The following is a description of a gene set: Leishmania major infected human dendritic cells (DCs) exhibit a marked induction of IL-12 ultimately promoting a robust Th1-mediated response associated with parasite killing and protective immunity. In this study, we utilized Affymetrix Genechips to globally assess the host cell genes and pathways associated with L. major infection during early infection (2, 4, 8, and 24 hrs) in human myeloid-derived DCs. Bioinformatic analyses of the hybridized microarray chips identified genes, represented by 848 unique probe sets, which, when compared to uninfected samples were observed to be significantly differentially expressed by one-way ANOVA. Altogether, the data provide a genome-wide perspective on the transcriptional influences Leishmania species exert within human DCs during early infection, and provides a platform for further investigations toward functionally characterizing candidate genes of importance to the IL-12 based immune response to infections. In the current study, we further investigate the L. major infected DC transcriptional during early time points after infection via microarray analysis. Genes up-regulated in dendritic cells: untreated versus 24h after infection of Leishmania major. Human Gene Set: GSE42088_UNINF_VS_LEISHMANIA_INF_DC_24H_UP studied in species Homo sapiens from publication Favila MA, Geraci NS, Zeng E, Harker B, Condon D, Cotton RN, Jayakumar A, Tripathi V, McDowell MA (PMID 24808365), and this is the list of marker genes: ZDHHC7, SUCLG2, NCOA3, KAT6B, EPRS1, CAST, IL10RA, SCPEP1, THEMIS2, RFC3, INPP4A, SF3B1, PCBP2, CCDC69, CHKA, SHB, KIAA0513, CASP9, LRRFIP1, TSPO, TXN2, CLCN3, NUCKS1, PHF20, CSDE1, LGALS9, RAD17, H1-10, PTK2B, ARHGAP45, PIGT, OXA1L, ZBED1, BAIAP2, ZFP36, SNRK, HMGB2, CENPC, POLB, PAK6, KLF4, RALGDS, CSF3R, MTMR12, EVI2A, FLI1, ZFP36L1, CSAD, SH3TC1, INPP5D, ITM2B, LBR, CELF2, SGSM2, ZNF117, MEF2C, HSPA14, PDK3, ACAP1, NACA, TSC22D3, PTPN22, ZBTB1, TLR4, ARHGAP4, SRSF5, SPATA20, VPS51, MACROH2A1, ALDH2, ZXDC, CBFA2T3, PIK3R1, ADPGK, CD302, CD69, RUNX3, EVI2B, TRMT5, FAM53C, RAP2B, HSD17B11, GSTK1, CYTH4, PPM1F, MANBA, IFNGR1, HLA-DMB, SPAST, MTX1, CRISPLD2, ZWILCH, RGS2, ASAH1, ABCB7, CSNK1G3, CSNK1G2, ITGA4, MAP3K2, ELF1, NLRP1, MXD1, PTGER4, SIPA1, TRAK1, DUSP1, DENND3, TACC1, CCNB1IP1, C5AR1, CERK, RNASET2, PRKCB, PECAM1, HMG20A, TYK2, TOR3A, RAB33B, ITGAM, PJA2 (praja ring finger ubiquitin ligase 2), CLEC7A, GAS7, IQSEC1, PTMA, GALNT11, COTL1, CD46, SLC25A46, AMPD2, PLBD1, NACA4P, ZFP36L2 (NCBI Gene Id 96706), PXN (NCBI Gene Id 80229), MID1IP1, INSR, DNAJC10, SLC2A4RG, PIGB, SPIN1, TAFAZZIN, GALNT10, MYLIP, SGSH, NEDD9, HMGB1, JUND, KLF2, SLC41A3, CASD1, GOLGA8H, SLA, HLA-DMA, LETMD1, NR4A2, ORC6, CAMLG, EGR1, DOCK2, CD86, EIF4B, RIN3, AGTPBP1 (NCBI Gene Id 23287), CEBPD, PHF3, EIF3E (NCBI Gene Id 3646), TRABD, MAN2A2, MINK1, ARL4C, ITGB2, VCAN, KCNAB2, RNF114, OSBPL9, LIPA, SIGIRR, ARHGEF1, GPX3, CD37, RHOB, MPPE1, TKT, MTMR1, NR4A1, RASSF2, PPFIBP2, DHRS3, TLE5, KCNQ1, LTA4H, ATG2A, HEXIM1, TNRC6B, RAB11FIP1, SUGP2, PGLS, SMCHD1, DOP1A, YPEL5, KLF3